The following is a description of a gene set: Mouse Gene Set: REACTOME_GAP_JUNCTION_TRAFFICKING_AND_REGULATION studied in species Mus musculus Gap junction trafficking and regulation, and this is the list of marker genes: Tubb2b, Tubb2a, Tuba1c, Gjd3, Tubb1, Tjp1, Tuba4a, Gja8, Ap2m1, Gja1, Cltb, Gjc1, Tuba1b, Dab2, Dnm1 (dynamin 1), Tuba1a, Gjd2, Gjb6, Gja4, Tubb3, Gjc2, Gjb4, Gja5, Gjb5, Gjb1, Actb, Dnm2, Clta, Gjb2, Tuba8, Gja10, Tubb4b, Gja3, Tuba3a, Myo6 (NCBI Gene Id 60360), Tubb4a, Actg1, Gjd4 (gap junction protein, delta 4), Tubal3, Cltc, Tubb6, Src, Tuba3b, Gjb3